The following is a description of a gene set: Reactome Pathway: Toll-like Receptor Cascades This event has been computationally inferred from an event that has been demonstrated in another species.<p>The inference is based on the homology mapping from PANTHER. Briefly, reactions for which all involved PhysicalEntities (in input, output and catalyst) have a mapped orthologue/paralogue (for complexes at least 75% of components must have a mapping) are inferred to the other species. species: Mus musculus part of: Innate Immune System electronically inferred by orthology from the curated human pathway, and this is the list of marker genes: Cul1, Tab2, Sftpd, Traf3, Mapk11, Dnm2, Mapk9, Ube2n, Peli2, Nfkbia, Plcg2, Tifa, Apob, Hsp90b1, Pik3c3, Ube2v1, Ube2d1, Ikbkb, Nlrx1, Ppp2r1b, Ctss, Ager, Tlr4, Ly96, Dusp6, Nkiras1, Nfkb1, Irak1, Vrk3, Rps27a, Mapk7, Dusp7, Tab3, Map3k8, Fos, Cd14, Hmgb1, Tasl, Unc93b1 (NCBI Gene Id 54445), Gsdmd, Birc3, Bpi (bactericidal permeablility increasing protein), Irf3, Cd36, Tlr9, Nlrc5, Ly86, Nfkb2, Itgb2, Ecsit, Map2k3, Rela, Mapk14, Tirap, Irf7 (interferon regulatory factor 7), Tlr8, Rbsn, Tlr7, Rps6ka5, Lgmn, Tlr2, Mapk8, Map2k4, Mapk3, Ppp2r5d, Ticam2, Fadd, Casp8, Irf5, Map2k6, Jun, Lbp, Lrrc14, Tlr6, S100b, Nfkbib, Ubb, Optn, Fgg, Tab1, Map2k7, Tlr1